The following is a description of a gene set: Catalysis of the hydrolysis of peptide bonds in a polypeptide chain by a mechanism in which a water molecule bound by the side chains of aspartic residues at the active center acts as a nucleophile. species: Mus musculus Mouse Gene Set: GOMF_ASPARTIC_TYPE_PEPTIDASE_ACTIVITY, and this is the list of marker genes: Casp3, Crb2, Sppl2c, Ncstn, Nlrp2, Bin1, Ctse, Pga5, Gapdhrt2, Sva, Psen2, Ren1, Ddi2, Bace1 (beta-site APP cleaving enzyme 1), Psen1, Pgc, Napsa, Nrip2, Sppl2a, Sval1, Cym, Wfdc2, Gapdh-ps15, Gapdh, Sppl2b, Sppl3, Sorl1, Nrip3, Cntnap5a, Gapdhrt, Ddi1, Prnp, Sval3, H13, Bace2, Ctsd, Sval2, Pip, Asprv1, Casp7, Astl